Given this list of marker genes PPP1R11, NEFM, CCNI, FUS, PLPP2, KCND3, CCL7, CDKN1C, SPRY2, EIF4A1, GNAS, MEF2D, FXYD2, GADD45B, TECR, PMS2P3, CEBPB, COPE, KPNA4, UQCRC1, TNNT1, PKP3, TACSTD2, ACTN4, CHMP2A, S100A12, HMG20B, PLD1, RPS9, DGAT1, TUBB4B, RAB5A, KLK1, NEDD8, CITED2, POLR2I, NXF1, CAPG, SMAD7, ACO2, RACK1, S100A11, VASP, DUSP14, SLC3A2, EIF4EBP2, SLURP1, H2BC10, CACNA1E (calcium voltage-gated channel subunit alpha1 E), KRT8 (keratin 8), SH3GL1, STX16, RALY, CSNK2B, BRD2, RNF24, NEU1 (NCBI Gene Id 4758), RAB9A, UBB, STOML2, LYPD3, PPP2R1A, MAFF, BTF3, ARHGDIA, RPL8, NPR1, CXCL3, SULT2B1, SLC6A8, RGS12, TXNRD1, YBX1, DKK1, EMD, NDEL1, DCTN1, VCP, TFE3, RND3, HCCS, CYP11B1, NME2, PTPRE, RXRA, EFNA1, PAX8, POLB, MUC1, RPL18, PRPF19, DRAP1, GTF2B, EMP3, EIF1, KYNU, STXBP2, CTH, TMF1, HLA-F (NCBI Gene Id 3134), ISG20, TMEM265 (NCBI Gene Id 100862671), CAP1, PFDN5 (prefoldin subunit 5), KLK10 (NCBI Gene Id 5655), HLA-G, TSPAN1, RPL14, RER1, DTNB, LY6E, PHLDA2, TGM2, CDK2AP2, MXD1, CGB3, HLA-DRB1, NR4A2, PFN1, SNRPB, ALDOA, ABL1, OAZ1, RECQL4, DNAJA1, EIF3F, IRF5, MSI1, ATP6V1F, PRPF3, PRSS1, TUFM, IDH3B, FOXC1, CDK16, CDK5, TST, TOB1, ADM, PNP, IFRD1, HMGA1, BTRC, UPK1B, TNFAIP3, SND1, CD99, RAC1, ATP5F1D, IFI30, ZNF211, CSRP1, MRPL23 (NCBI Gene Id 8046), EYA2, RPL10, BTG3, SPINT1, LAD1, ULK1 (NCBI Gene Id 8408), KLF5, NECTIN2, MPG, P2RY11, HMGCS2, WASL, ACOX1, ADRA1D, GEM, GPR143, H3C4, ZNF165, BANF1, RABAC1, SLC1A6, STK17B, MMP10, TAF7, GADD45A, KRT75, PRB4, SNAPC1, RGS16, GSN, RAE1, TRAF4, RFC2, EIF3I, LY6G6C, NDUFS8, RAB1A, TNFRSF1B, AREG (amphiregulin), GRN, PRB1, PSME1, VAT1, HLA-E, H3C10, GABARAP, MAGED2, ENDOG (endonuclease G), TRIM15, ATF3, CST6, KRT7, UBE2D3, EIF6, APRT (NCBI Gene Id 353), GCHFR, UBE2M, MYCN, PMVK, CX3CL1, CXCL2, FOLR1, CYP19A1, DNAJB6, COX5B, MPDU1, ANXA2, CSNK1D, CTSD, RPS11, HLA-B, POLD4, ATF4, POLR2L, MRPS12, CXCL1, CDC37, GJB3, STX11, IL1B, MNAT1, BUD31, TGFB1, CD4, CDKN1A, TRIB1, ATP6V0A1, ZNHIT1, CRYAB, PLIN3, UBE2H, TRIM28, IER2, ODC1, RNH1, JUNB, PTGS1, EIF3G, API5, SEPTIN5, ECH1, C1R, ALAS1, TRIM29, KCNB2, TXN2, EIF3C, PEA15, TIMM44, EVX1, KCNQ3, RHOD, LGALS1, ZNF263, POLA2, ETS2, HNF1B, NDUFB7, RRAD, TIMM17B, LIG4, CITED1, PSMB7, PPP1R15A, BLCAP, EIF4E2, MLF2, DPM2, CASP1, SRPRA, AKR1B1, JUND, MAP2K3, COX7A1, KLK11, TSC22D1, PPP2R2A, SGK1, MIF, YTHDC1, BPGM, CFL1, CYP17A1, NOP2, APOE, QPCT, SSR4, INSL4, CCNC, ATP6V0B, TCIRG1, ENG, KRT33B, FAU, RPL19, BSG, LY6D, AMD1, DNAJB2, CKMT1B, PSMB4, TGIF1, SELPLG, RPS5, LIG1, CDH16, TALDO1 (transaldolase 1), CGGBP1, RPL10A (ribosomal protein L10a), SDC4, ATG12, DGCR6, PHKG1, SORBS3, PPBP, JTB, TUBB4A, CLK1, PLD2, DXO, TCF15, F2RL1, MAD1L1, TIMM17A, PPP1CA, RPL18A, TMED3, CCN1 (cellular communication network factor 1), CLDN4, CRHR1, TGM3, EIF5, YWHAZ, IER3, EFNB1, PSMD9, SKP1, ECHS1, SF3B4, PMEL, PHB2, SARS1, CEBPG, PIGQ, TKTL1, ALDH3B2, EIF1B, PCBP1, RPS15, CCK, HBP1, CIB1, DUSP1, SCN2B, RBM4, HMBS, PCSK7, ZNF593, PPP4C, FKBP2, RPN1, P4HB, ACAA1, PSMB3, ERCC1, LAMA2, ITPR1, SERPINB6, ECM1, BLVRB, MOAP1, SNTA1, ELL2, TUBB2A, GSTP1, KRT34, ITM2B, ZFP36, SPINK1, PSG7, SMPD1, CRABP2 (cellular retinoic acid binding protein 2), ERGIC3, ST3GAL2, CCL14, TAGLN, SLC25A14, HLA-A, PRL, SURF1, UBXN1, HSPB1, NAALADL1, PEPD, SERPINB8, COX6B1, TROAP, HSP90AB1, NME4, AQP6 (NCBI Gene Id 363), CYC1, ACOX2, NR1D1, UBQLN2, PRDX2, FAM50A, PTOV1, ST7, ASL, MGAT3, ACADVL, ATP6V0C, COX6A1, NTHL1, CCNT2, MAP1LC3B, VAMP8, MAL, DUSP8, BRS3, GUK1, MCM3, COMT, SELENOW, JUP, TOM1, LY6H, RPL12 (ribosomal protein L12), CHRNB1, H2BC14, PSMD8, EVPL, SUPT4H1, RFC1, POLR2A, ZNF76, PPIF, TAGLN3, GPX4, GAST, EIF3K, CSH1, CLP1, GALNT3, HPCA, MAPK13, MMP14, CYTH2, FOS, AP1G2, KCNG1, PRSS8, DHRS2, PYY, BCKDK, BAMBI, ATP6V1E1, IL1R2, H2AC16, OVOL1, ATP6V0E1, KLK8, H2BC15, DDT, ITGB7, TNFSF9, RPS10, CDA, ELOB, B2M, ATP5F1A, CEBPA, TAGLN2 (transgelin 2), SF3A1, NUCB1, GPS2, GABARAPL2, AP2S1, PHKG2, VPS72, H1-3, PSMB8, RPL29 (NCBI Gene Id 6159), PER1, SSR1, BTG1, FHL2, SCAMP3, RBBP6, CCNA1, TRPV6, SLC12A4, IGFBP6, GNB2, ALOX12 (arachidonate 12-lipoxygenase, 12S type), DUSP5, GDI1, CKB, RNF103, CYBA, ASNS, RPS3, CLTA, PDLIM4, ENO1, H2BC4, RPL28, UBA1, PTH1R, GLA, HBEGF (heparin binding EGF like growth factor), MGMT, RPL35, EPHB3, ISG15, RPS21, CCN2, KRT18, FMNL1, LGMN, here is a description of the gene set: Human Gene Set: ENK_UV_RESPONSE_KERATINOCYTE_UP Genes up-regulated in NHEK cells (normal epidermal keratinocytes) after UVB irradiation. from publication Enk CD, Jacob-Hirsch J, Gal H, Verbovetski I, Amariglio N, Mevorach D, Ingber A, Givol D, Rechavi G, Hochberg M (PMID 16434974) studied in species Homo sapiens In order to obtain a comprehensive picture of the molecular events regulating cutaneous photodamage of intact human epidermis, suction blister roofs obtained after a single dose of in vivo ultraviolet (UV)B exposure were used for microarray profiling. We found a changed expression of genes. Half of the UVB-regulated genes had returned to pre-exposure baseline levels at 72 h, underscoring the transient character of the molecular cutaneous UVB response. Of special interest was our finding that several of the central p53 target genes remained unaffected following UVB exposure in spite of p53 protein accumulation. We next compared the in vivo expression profiles of epidermal sheets to that of cultured human epidermal keratinocytes exposed to UVB in vitro. We found genes that differed in their expression profiles between the two groups. The expression profile in intact epidemis was geared mainly towards DNA repair, whereas cultured keratinocytes responded predominantly by activating genes associated with cell-cycle arrest and apoptosis. These differences in expression profiles might reflect differences between mature differentiating keratinocytes in the suprabasal epidermal layers versus exponentially proliferating keratinocytes in cell culture. Our findings show that extreme care should be taken when extrapolating from findings based on keratinocyte cultures to changes in intact epidermis.